The following is a description of a gene set: Human Gene Set: WP_IL3_SIGNALING IL3 signaling species: Homo sapiens, and this is the list of marker genes: JAK2, VAV1, CBL, YWHAQ, PIK3R2, MAPK3, YWHAB (tyrosine 3-monooxygenase/tryptophan 5-monooxygenase activation protein beta), PTPN11, TGFB1, STAT5B, PIK3CD (NCBI Gene Id 5293), JAK1, JUN, FOS, RAF1, HCK, SOS1, STAT3, GRB2, LYN, CD69, RAPGEF1, SRC, CD86, CRKL (CRK like proto-oncogene, adaptor protein), IL5RA, STAT5A, PIK3R1, CXCL8, HRAS, MAPK1, BCL2, MAPK8, BAD, SHC1, ENPP3, IL3RA, AKT1, INPP5D, MAP2K1, BCL2L1, IL3, CCR3, CSF2RB, FYN, SYK, PRKACA, GAB2, PTPN6